The following is a description of a gene set: The process whose specific outcome is the progression of a lymph vessel over time, from its formation to the mature structure. studied in species Homo sapiens Human Gene Set: GOBP_LYMPH_VESSEL_DEVELOPMENT, and this is the list of marker genes: ACVR2B, EPHA2, PTPN14, PPP3CB, FGF2, NR2F2, TBX1, KDR, SOX18, FLT4, MIR9-1, ACVRL1, CLEC14A, PKD1, PTPN20, BMPR2, HEG1, VEGFA, EFNB2, VASH1, LGALS8, TIE1, CCBE1, PROX1, TMEM204, VEGFC, SYK, PDPN, SVEP1, FOXC1, NPR2, FOXC2